Given this list of marker genes ABCC8, EIF2AK3, KCNJ11, GCK, INS, STAT3, PDX1, here is a description of the gene set: Reduced number of beta cells in the pancreatic islets of Langerhans. Human Gene Set: HP_REDUCED_PANCREATIC_BETA_CELLS studied in species Homo sapiens Reduced pancreatic beta cells